Given this list of marker genes Ccdc38, Rnf169, Dnajc2, Trp53bp1, Usp15, Uimc1, Jarid2, here is a description of the gene set: A histone reader that recognizes a histone bearing a ubiquinated lysine residue. species: Mus musculus Mouse Gene Set: GOMF_UBIQUITIN_MODIFIED_HISTONE_READER_ACTIVITY